Given this list of marker genes Tgfb1, Nectin2, Klrk1, Il12a, Klre1, Cd226, Pvr, Crtam, Havcr2, Il12b, Cd160, Ceacam1, here is a description of the gene set: studied in species Mus musculus Any process that modulates the frequency, rate, or extent of natural killer cell mediated immune response to a tumor cell. Mouse Gene Set: GOBP_REGULATION_OF_NATURAL_KILLER_CELL_MEDIATED_IMMUNE_RESPONSE_TO_TUMOR_CELL